Given this list of marker genes CBX3, PHC3, CDC7, RYBP, RRM2, BRCA1, RBBP4, EHMT1, CBX5, L3MBTL2, PCGF6, SUZ12, MAX, BMI1, TFDP1, UXT, RBBP8 (RB binding protein 8, endonuclease), EHMT2, EZH2, EED, PHC1, E2F6, RAD51, CHEK1, YAF2, E2F1, MGA, APAF1, EPC1, TFDP2, RBBP7, RING1, PCGF2, RNF2 (NCBI Gene Id 6045), here is a description of the gene set: part of: Generic Transcription Pathway Reactome Pathway: Transcriptional Regulation by E2F6 species: Homo sapiens E2F6, similar to other E2F proteins, possesses the DNA binding domain, the dimerization domain and the marked box. E2F6, however, does not have a pocket protein binding domain and thus does not interact with the retinoblastoma family members RB1, RBL1 (p107) and RBL2 (p130). E2F6 lacks the transactivation domain and acts as a transcriptional repressor. E2F6 forms a heterodimer with TFDP1 (DP-1) or TFDP2 (DP-2).<p>E2f6 knockout mice are viable and embryonic fibroblasts derived from these mice proliferate normally. Although E2f6 knockout mice appear healthy, they are affected by homeotic transformations of the axial skeleton, involving vertebrae and ribs. Similar skeletal defects have been reported in mice harboring mutations in polycomb genes, suggesting that E2F6 may function in recruitment of polycomb repressor complex(es) to target promoters.<p>E2F6 mediates repression of E2F responsive genes. While E2F6 was suggested to maintain G0 state in quiescent cells, this finding has been challenged. Instead, E2F6-mediated gene repression in proliferating (non-quiescent) cells is thought to repress E2F targets involved in G1/S transition during S phase of the cell cycle. E2F6 does not affect E2F targets involved in G2/M transition. In the context of the E2F6.com-1 complex, E2F6 was shown to bind to promoters of E2F1, MYC, CDC25A and TK1 genes. E2F6 also binds the promoters of CDC6, RRM1 (RR1), PCNA and TYMS (TS) genes, as well as the promoter of the DHFR gene. While transcriptional repression by the E2F6.com 1 complex may be associated with histone methyltransferase activity, E2F6 can also repress transcription independently of H3K9 methylation.<p>During S phase, E2F6 is involved in the DNA replication stress checkpoint. Under replication stress, CHEK1-mediated phosphorylation prevents association of E2F6 with its target promoters, allowing transcription of E2F target genes whose expression is needed for resolution of stalled replication forks and restart of DNA synthesis. Inability to induce transcription of E2F target genes (due to CHEK1 inhibition or E2F6 overexpression) leads to replication stress induced DNA damage. E2F6 represses transcription of a number of E2F targets involved in DNA synthesis and repair, such as RRM2, RAD51, BRCA1, and RBBP8.